The following is a description of a gene set: studied in species Homo sapiens Human Gene Set: MIR6853_3P Genes predicted to be targets of miRBase v22 microRNA hsa-miR-6853-3p in miRDB v6.0 with MirTarget v4 prediction scores > 80 (high confidence targets). from publication Chen Y, Wang X (PMID 31504780), and this is the list of marker genes: SCAI, RXFP1, CCNT2, LRRN3, AASDHPPT, ELAPOR2, MSR1, UVRAG, NEXMIF, DMXL1, SECISBP2, SPOPL, C1orf21, SNTG1, GLRX2, SPRED1, ATL3, NTAQ1, AHCTF1, DCLRE1B, ROBO2, GTDC1, ZFPM2, PPP2CA, AASS, SSTR1, FUT11, SDHA, GRIA4, SAR1A, RBPJ, RPGR, KPNA4, ACYP2, PARP12, ELP4, RHOJ, TM6SF1, MEIOC (meiosis specific with coiled-coil domain), MOSMO, PSG3 (pregnancy specific beta-1-glycoprotein 3), CPEB2, DOK6, SMAD7, CEP57L1, HELB, IRAK3, ZFC3H1, KIAA1549L, FREM2, FAM120A, PSAT1, FLRT3, OTP, LIMCH1, KMT5B, RDH12, FMR1, CABP4, PTPRM, UQCR11, POLI, ADGRL3, CSF2RB, KCND2, CDH13, GCNT2, SLC4A5, WDR72, ITGAV, SPCS3, ZNF546, CCPG1, YAF2, DCLK1, ARHGAP21, ITGB1, PSG5 (pregnancy specific beta-1-glycoprotein 5), NUS1, RPS6KB1, TCP11L2, SGIP1, ALDH3A2, PTPN1, PRKAR2A, CPLX3, HPGD, ATP2C1, CDCA2, MIER3, UFM1, TCEAL8, UBE2G1, DIP2C, HSPD1, PPP1R3E, SPATA9, SLAMF1, GAP43 (NCBI Gene Id 2596), LILRB4, TIMM8A, SLC35A3, AVIL (advillin), RIMKLB, CTBS, SLCO3A1, RMND5A, ZBTB11 (zinc finger and BTB domain containing 11), RNF138, AHDC1, P2RX2, CCN2, CXCL5, FAM47A, CDH11, EP300 (NCBI Gene Id 2033), USP47, ADSS2, OXGR1, POC1B, CA13, C1orf52, ZBTB10, ZKSCAN1, SMCHD1, GABRG1, C6orf62, SLC6A11, NIPSNAP2, GVQW3, ARIH1 (ariadne RBR E3 ubiquitin protein ligase 1), APC, RSU1, ACTRT3, ATG5, UHRF1, SPRY3, RIMS2, HS2ST1, CT55, PSG2, KCNK1, HDAC8, MCCC2, DENR, KLF12, QKI, TMPRSS12, DOLPP1, PROSER1, PHF20L1, SLC27A2, KLF4, CLRN1, TCOF1, ZFHX3, GLYR1, ATP1B1, WDTC1, EBF2, ATP2A2, IL5RA, RYR2, PACSIN2, UBE3A, RABIF, TBC1D4, MLIP, CEP44, ACKR4, FIGN, ZNF624, ZSCAN1, CSAG1, RPS6KA3, SOX6, SMNDC1, RHD, UBXN2B, ZNF782, HIRA, RSAD1, TDRP, COL14A1, MEGF9, CCL28, ARFGAP3, PMPCB, TIMM23B, PWWP2A, PIGL, TMEM229A, TRMT9B, SH3RF3, GANC, NRP1, MAP4K5, UBE4A, IGSF10, SLC66A3, USP46, GRIK2, BIRC6, ACVR2A, PDS5B, WDFY3, KATNAL2, CRISPLD2, SPAG9